The following is a description of a gene set: Genes positively differentially expressed in cell type: NK cell upon treatment with cytokine: LT-α2/β1 in mouse lymph nodes in vivo. Mouse Gene Set: CUI_NK_CELL_LTA2_B1_RESPONSE_UP Cytokines mediate cell-cell communication in the immune system and represent important therapeutic targets. A myriad of studies have highlighted their central role in immune function, yet we lack a global view of the cellular responses of each immune cell type to each cytokine. To address this gap, the authors created the Immune Dictionary, a compendium of single-cell transcriptomic profiles of more than 17 immune cell types in response to each of 86 cytokines (>1,400 cytokine-cell type combinations) in mouse lymph nodes in vivo. A cytokine-centric view of the dictionary revealed that most cytokines induce highly cell-type-specific responses. For example, the inflammatory cytokine interleukin-1β induces distinct gene programmes in almost every cell type. A cell-type-centric view of the dictionary identified more than 66 cytokine-driven cellular polarization states across immune cell types, including previously uncharacterized states such as an interleukin-18-induced polyfunctional natural killer cell state. species: Mus musculus from publication Cui A, Huang T, Li S, Ma A, Pérez JL, Sander C, Keskin DB, Wu CJ, Fraenkel E, Hacohen N (PMID 38057668), and this is the list of marker genes: Tmsb10, Phb1, Ola1, Proser1, Erh